Given this list of marker genes Ube3a, Gria1 (glutamate receptor, ionotropic, AMPA1 (alpha 1)), Stmn2, Trpv1, Cdc5lrt10, Kidins220, Eef2k, E2f1, Tmem108, Bdnf, Cdc5l, Grip1, Gria2, Cdc5lrt7, Ntf3, Cstf2, Sort1, Cdc5lrt4, Sh3gl2, Nfkb1, Tac1, Cbl, Cib1, Cd2ap, Hes1, Dlg1, Cdc5lrt6, Calca, Micall1, Cdc5lrt8, Parp1, Acap2, Ngf, Cdc5lrt1, Cdc5lrt5, Usp8, Csnk1e, Coro1a, Braf, Gad2, Ehd1, Foxo3, Elavl4, Magi2, Rapgef1, Arf6, Wasf1, Rap1a, Ntrk3, Cdc5lrt9, Rab35, Ntrk1, Ntf5, Dync1li2, Kcnc2, Kat2a, Crk, Kcnc1, Ntrk2, Rps3, Ptpn1, Rapgef2, Akt1, Shoc2, Dync1li1, here is a description of the gene set: A process that results in a change in state or activity of a cell or an organism (in terms of movement, secretion, enzyme production, gene expression, etc.) as a result of a nerve growth factor stimulus. species: Mus musculus Mouse Gene Set: GOBP_RESPONSE_TO_NERVE_GROWTH_FACTOR